Given this list of marker genes RRP15 (NCBI Gene Id 57241), RALGPS2, CMTR1, TRABD2B, TMEM215, NXF1, VPS53, GPD2, UBE2QL1, RPL28, C19orf73, PUS3, ANKH, AGPAT3, OGG1, PLXDC2, CDC42BPA, ATP1B1, CASP2, RALBP1, ZNF708, LSM5, C8orf58, NPNT, SRSF7, CCND1 (cyclin D1, NCBI Gene Id 893), FAM168A, SERPINB13, TOGARAM1, CPLX2, ARMCX3, TP63, NR2C2, INO80D, NRIP3, PTPRJ, RFWD3, SH3PXD2A, KIF1C, KCNJ10, RPP14, MED19, TMEM201, PDPK1, ZFR2, A1CF, CUTC, TMED1, PHTF2, EVC, GGCX, SMUG1, MORC3, SORCS1, HOMER1, TNRC6A, UBIAD1, MYO1F, GRIK2, CRKL, RIC3, CYTL1, DIS3, EDN2, PAX5, ADORA2B, ZSCAN5A, CAMTA1 (NCBI Gene Id 23261), MBNL1, CALN1, SLC6A15, PCDH17, MEX3B, TMEM95, WDR31, INSIG2, LPCAT3, SARS1, TANC2, TNRC6B, here is a description of the gene set: Genes predicted to be targets of miRBase v22 microRNA hsa-miR-8073 in miRDB v6.0 with MirTarget v4 prediction scores > 80 (high confidence targets). studied in species Homo sapiens from publication Chen Y, Wang X (PMID 31504780) Human Gene Set: MIR8073